The following is a description of a gene set: The mitochondrial carnitine system catalyzes the transport of long-chain fatty acids into the mitochondrial matrix where they undergo beta oxidation. This transport system consists of the malonyl-CoA sensitive carnitine palmitoyltransferase I (CPT-I) localized in the mitochondrial outer membrane, the carnitine:acylcarnitine translocase, an integral inner membrane protein, and carnitine palmitoyltransferase II localized on the matrix side of the inner membrane. (Kerner & Hoppel, 2000; Ramsay et al. 2001). Additional reactions annotated here enable the uptake of carnitine and the regulation of fatty acid biosynthesis at the level of ACACA and ACACB to minimize simultaeous mitochondrial catabolism and cytosolic biosynthesis of long-chain fatty acids. studied in species Homo sapiens Reactome Pathway: Carnitine shuttle part of: Fatty acid metabolism, and this is the list of marker genes: RXRA, ACACA, PRKAB2, PRKAA2, MID1IP1, CPT1A, SLC22A5, CPT1B, THRSP, CPT2, PPARD, PRKAG2, SLC25A20, ACACB